The following is a description of a gene set: Any process that results in a change in the behavior of an organism as a result of an ethanol stimulus. Human Gene Set: GOBP_BEHAVIORAL_RESPONSE_TO_ETHANOL species: Homo sapiens, and this is the list of marker genes: HDAC2, CRHBP, FGF2, USP46, EPS8, OPRM1, DRD2, DBH, CRHR1, DRD4